Given this list of marker genes CSF2RA, LAMTOR1, WIZ, SCAP, MRPL46, RPUSD4, MATCAP1, UBAC1 (UBA domain containing 1), NIP7, SLAMF1, CHRNA1, SH2B1, DNAAF2, H1-1, RPS5, SNU13, ARSG, SWAP70, ARHGEF9, OXA1L, PLCB2, ATPAF2, PRR36, RPL13AP5, RPL26, F13B, TADA1, LGALS1, PLCB3, PPM1F (protein phosphatase, Mg2+/Mn2+ dependent 1F), BLOC1S6, TSHZ1, C11orf24, UBE3D, APBA1, GPX4, ATP5PB, HFM1, MFAP5, MMACHC, ZIK1, SERBP1, TACC3, ITGAV, THAP12, RPL6, USP36, TTC9, SAT2, BCO2, MRI1, ART4, RCAN1, RAPH1, MMS19, LGR4, ARAF, CFAP251, AIFM1, CAMKMT, MORC2, RNF180, RPL23A, FAF1, FGFR1, CCNYL3, SUGT1P3, OR7E24, NQO1, TEF, TACR3, LCA5, UBTF, CRH, RPL13AP20, TMEM185B (transmembrane protein 185B), TTYH2, ADH4, RPS17, CYREN, EIF2D, MNAT1, AMACR, LGALSL, EMC3-AS1, MRFAP1L2, PPP1R16B, PITRM1, OTULIN, EEFSEC, FZD1, AASDHPPT, TOP1MT, GFOD1, MTFMT, RASSF2 (NCBI Gene Id 9770), SRSF8, FRMD6, ZNF416, SNORD60, UBIAD1, SDC2, NUDT9P1, EMD, BLTP2, ZFYVE9, CFAP61, RPL36A, RPLP0, ZDHHC2, PGBD1, CELF1, C3orf33, CD52, RMND5A, STXBP5, SRGAP1, NCALD, MAP3K4, HHLA2, SLC8B1, BIN3, ZNF839, FAM171A2, SMYD3, CCNB1IP1, OR2M3, IL16, MPC2, HDAC9, RNF216, OXSM, ITGB1BP1, PIDD1, URI1, MRPS2, IMPDH2, RPL35, XPNPEP2, GLS, SNORD28, MAP4K4, GTF3C2, CAPN2, REP15, ARHGEF1, THEM4, RPLP2, MIR197, ESYT1, AMMECR1, SNAI1, RPS13, C1orf141, RXRB (retinoid X receptor beta), TIAL1, NDUFB10, EIF3L, PTGER3, MIR516B2, PRDM5, DAGLA, CALCRL, ZNF570, MMD, TIPIN, PROS1, ZNF789, ZNF551, LINC02871, SCAI, NTS, MTCL1, LCN1P1, RRS1, ATP13A5, TTC13, DHRS2, COMMD6, CPT2, MAGED2, H4C9, RPL7A, GSTP1, TNFAIP8L2, ZNF398, PPIL6, NDUFAF7, ZNF785, SRCAP, PCGF1, ZNF137P, CCNF, TTC5, TMEM9, FBL, ALMS1, MTMR12, here is a description of the gene set: Regulatory T (Treg) cells, whose identity and function are defined by the transcription factor Foxp3, are indispensable for immune homeostasis. It is unclear whether Foxp3 exerts its Treg lineage specification function through active modification of the chromatin landscape and establishment of new enhancers or by exploiting a pre-existing enhancer landscape. Analysis of the chromatin accessibility of Foxp3-bound enhancers in Treg and Foxp3-negative T cells showed that Foxp3 was bound overwhelmingly to pre-accessible enhancers occupied by its cofactors in precursor cells or a structurally related predecessor. Furthermore, the bulk of Foxp3-bound Treg cell enhancers inaccessible in Foxp3- CD4+ cells became accessible upon T cell receptor activation prior to Foxp3 expression with only a small subset associated with several functionally important genes being exclusively Treg cell-specific. Thus, in a late cellular differentiation process Foxp3 defines Treg cell functionality in an “opportunistic” manner by largely exploiting the preformed enhancer network instead of establishing a new enhancer landscape. Human Gene Set: GSE40685_NAIVE_CD4_TCELL_VS_TREG_UP from publication Samstein RM, Arvey A, Josefowicz SZ, Peng X, Reynolds A, Sandstrom R, Neph S, Sabo P, Kim JM, Liao W, Li MO, Leslie C, Stamatoyannopoulos JA, Rudensky AY (PMID 23021222) Genes up-regulated in CD4: naïve versus FOXP3+ T reg. species: Homo sapiens